The following is a description of a gene set: species: Homo sapiens Human Gene Set: KLEIN_PRIMARY_EFFUSION_LYMPHOMA_DN from publication Klein U, Gloghini A, Gaidano G, Chadburn A, Cesarman E, Dalla-Favera R, Carbone A (PMID 12531789) AIDS-related primary effusion lymphoma (PEL) is an HIV-associated malignancy characterized by the ability of the tumor cells to specifically home in the serous body cavities. Here we used gene expression profile analysis (about genes) to further define the phenotype of PEL and to investigate the lymphoma relationship to normal B cells and to other tumor subtypes, including non-Hodgkin lymphomas (NHLs) of immunocompetent hosts and AIDS-associated NHL (AIDS-NHL). The results showed that PEL displayed a common gene expression profile that is clearly distinct from all NHLs of immunocompetent hosts and AIDS-NHL subtypes and, in contrast to those, is not related to germinal center (GC) or memory B cells. The gene expression profile of PEL was defined as plasmablastic because it showed features of both immunoblasts identified by Epstein-Barr virus (EBV)-transformed lymphoblastoid cell lines and AIDS immunoblastic lymphoma, and plasma cells, as defined by multiple myeloma cell lines. Finally, our results identify a set of genes specifically expressed in PEL tumor cells. Their expression was validated at the protein level, suggesting their potential pathogenetic and clinical significance. Genes down-regulated in AIDS-related primary effusion lymphoma (PEL) samples compared to other tumor subtypes and normal B lymphocytes., and this is the list of marker genes: SEL1L3, CXCR5, BLNK (B cell linker), CD24, NCF4, ST6GAL1, PAWR, TMEM131L, RIPOR2, HLA-DQB1, SCRN1, ZHX2, ID3, GPX7, CCDC6 (NCBI Gene Id 8030), MS4A1, IGHV5-78, BIRC3, STX7, CD79B, CD79A, DEK, SPIB, PKIG, CTSH (cathepsin H), MSL3, ETS1, BTG2, MAPRE2, TRAF5, CD27, IRF8, DBI, SWAP70, PTPN6, ALDH5A1, HLA-DMB (NCBI Gene Id 3109), SIT1, RASSF2, CD52, CD22, CD72 (NCBI Gene Id 971), VNN2, MMD, HLA-DMA, CD19, IRAG2, CAPG, FADS3, BCAR3, GSTP1, BCL11A, TLE5, SYPL1, CD40, POU2F2, SH3BP5, GATM